The following is a description of a gene set: Non-small cell lung cancer (NSCLC) cells with somatic mutations in K-ras recruit to the tumor a variety of cell types (hereafter collectively termed stromal cells) that can promote or inhibit tumorigenesis by mechanisms that have not been fully elucidated. Here, we postulated that stromal cells in the tumor microenvironment alter the tumor cell secretome, including those proteins required for tumor growth and dissemination, and we developed an in vitro model to test this hypothesis. Coculturing a murine K-ras mutant lung adenocarcinoma cell line (LKR-13) with a murine lung stromal cell (macrophage, endothelial cell, or fibroblast) enhanced stromal cell migration, induced endothelial tube formation, increased LKR-13 cell proliferation, and regulated the secretion of proteins involved in angiogenesis, inflammation, cell proliferation, and epithelial-to-mesenchymal transition. Among these proteins, CXCL1 has been reported to promote NSCLC development, whereas interleukin-18 (IL-18) has an undefined role. Genetic and pharmacologic strategies to inhibit CXCL1 and IL-18 revealed that stromal cell migration, LKR-13 cell proliferation, and LKR-13 cell tumorigenicity required one or both of these proteins. We conclude that stromal cells enhanced LKR-13 cell tumorigenicity partly through their effects on the secretome of LKR-13 cells. Strategies to inhibit tumor/stromal cell interactions may be useful as therapeutic approaches in NSCLC patients. Proteins secreted in co-culture of LKR-13 tumor cells (non-small cell lung cancer, NSCLC) and MEC stroma cells (endothelium). Mouse Gene Set: ZHONG_SECRETOME_OF_LUNG_CANCER_AND_ENDOTHELIUM studied in species Mus musculus from publication Zhong L, Roybal J, Chaerkady R, Zhang W, Choi K, Alvarez CA, Tran H, Creighton CJ, Yan S, Strieter RM, Pandey A, Kurie JM (PMID 18757440), and this is the list of marker genes: Sdc4, Alad, Lgals3bp, Ldha, Rpl10a, Ahsg, Ctsz, Ctsl, Cp, Prl2c2, Igfbp4, Prdx1, Actb, Anxa3, Serpinc1, Ctsd, Trf, A2m (alpha-2-macroglobulin), Gm5138 (NCBI Gene Id 380687), Vcam1, Srsf2, Clu, Cfl2, Pzp, Tpm3, Mug1 (murinoglobulin 1), Tubb5, Clstn1, Ppib, Eef1a2, Vcl, Cdh1, Vcp, Kctd7, Bgn, Igfbp7, Vim, Ywhag, Ywhae, Glo1, Ran, Spp1, Pcna, Cfb, Fn1, Pebp1, Ctsa, Tpi1, Cx3cl1, Gapdh, Got1, Tpt1, Serpinb6a, Hmgb1, Tuba1c, Tnxb, Tkt, Phactr4, Aldoa, Col1a1, C2, Mdh2, Alb, Col18a1, Aldh3a1, Actc1, Eno1, Arhgdia, Eef2, Ywhaz